The following is a description of a gene set: studied in species Homo sapiens Human Gene Set: REACTOME_NOTCH4_ACTIVATION_AND_TRANSMISSION_OF_SIGNAL_TO_THE_NUCLEUS NOTCH4 Activation and Transmission of Signal to the Nucleus, and this is the list of marker genes: PSENEN, NCSTN, JAG1, APH1A, APH1B, PSEN1, PSEN2, DLL4, NOTCH4, ADAM10, YWHAZ